Given this list of marker genes EREG, ESR1, GPR149, PTX3, GAS2, ZP3, NPR2, TNFAIP6, FOXO3, NPPC, BMPR1B, SCAPER, here is a description of the gene set: Human Gene Set: GOBP_ANTRAL_OVARIAN_FOLLICLE_GROWTH Increase in size of antral follicles due to cell proliferation and/or growth of the antral cavity. studied in species Homo sapiens